Given this list of marker genes Adamts9, Bcl2, Zeb2, Adamts20, Kitl, here is a description of the gene set: Any process that activates or increases the frequency, rate or extent of melanocyte differentiation. species: Mus musculus Mouse Gene Set: GOBP_POSITIVE_REGULATION_OF_MELANOCYTE_DIFFERENTIATION